The following is a description of a gene set: Human Gene Set: MIKKELSEN_ES_LCP_WITH_H3K27ME3 Genes with low-CpG-density promoters bearing H3 trimethylation mark at K27 (H3K27me3) in embryonic stem cells (ES). studied in species Mus musculus from publication Mikkelsen TS, Ku M, Jaffe DB, Issac B, Lieberman E, Giannoukos G, Alvarez P, Brockman W, Kim TK, Koche RP, Lee W, Mendenhall E, O'Donovan A, Presser A, Russ C, Xie X, Meissner A, Wernig M, Jaenisch R, Nusbaum C, Lander ES, Bernstein BE (PMID 17603471) We report the application of single-molecule-based sequencing technology for high-throughput profiling of histone modifications in mammalian cells. By obtaining over four billion bases of sequence from chromatin immunoprecipitated DNA, we generated genome-wide chromatin-state maps of mouse embryonic stem cells, neural progenitor cells and embryonic fibroblasts. We find that lysine 4 and lysine 27 trimethylation effectively discriminates genes that are expressed, poised for expression, or stably repressed, and therefore reflect cell state and lineage potential. Lysine 36 trimethylation marks primary coding and non-coding transcripts, facilitating gene annotation. Trimethylation of lysine 9 and lysine 20 is detected at satellite, telomeric and active long-terminal repeats, and can spread into proximal unique sequences. Lysine 4 and lysine 9 trimethylation marks imprinting control regions. Finally, we show that chromatin state can be read in an allele-specific manner by using single nucleotide polymorphisms. This study provides a framework for the application of comprehensive chromatin profiling towards characterization of diverse mammalian cell populations., and this is the list of marker genes: MRGPRG, CACNA1S, PDE2A, MYLK2 (NCBI Gene Id 85366), SAXO4, TREM2, SOST, IL13 (interleukin 13), KCNN1, PPY, HTR3B, CRYBB1, MYL2, CHRM1